The following is a description of a gene set: from publication Chen Y, Wang X (PMID 31504780) Mouse Gene Set: MIR_6386 Genes predicted to be targets of miRBase v22 microRNA mmu_miR_6386 in miRDB v6.0 with MirTarget v4 prediction scores > 80 (high confidence targets). studied in species Mus musculus, and this is the list of marker genes: Calhm5, Tab3, Hps3, Eid2b, Naf1, Epha4, Pls3, Rad51b, Fam168a, Atp2c1, Srrm2, Crppa, Eif1a, Kcnk10, Emc1, Raver2 (NCBI Gene Id 242570), Eif1ad3, Serpinb13, Sestd1, Klf13, Kras, Nkd1, Atrx, Tex13c1, Sft2d3, Nab1, Prpf4b, Rcor1, Gatm, Slc10a2, Ap3s1 (adaptor-related protein complex 3, sigma 1 subunit), Bhlhb9, Eif1ad7, Cenpu, Cyp2c50, Kcnd2 (NCBI Gene Id 97339), Smarcc1, Slc25a46, Loxl2, Atrnl1, 2310039H08Rik, Abcd2, Mob1a, Frs2, Acbd5, Faap24, Rab11a (RAB11A, member RAS oncogene family), Sub1, Rc3h2, Mblac2, Osbpl11, Cdk6, Pygo1, Hycc2, Cep97, Fmo9